The following is a description of a gene set: Aplasia/Hypoplasia of the skin species: Homo sapiens Human Gene Set: HP_APLASIA_HYPOPLASIA_OF_THE_SKIN, and this is the list of marker genes: CHRNG, DDR2, BRAF, TP53, CTNNB1, CPLX1, UBR1, WRAP53, USP48, PRKAR1A, THBS2 (thrombospondin 2), NFIX, PROC, PTDSS1, ABL1, ZMPSTE24, DLL4, ARFGEF2, GNA11, EFEMP1, DKC1, TINF2, XPA, GORAB, TAF1, CHUK, ZNRF3, TNFRSF1B, SOX18, COL12A1, TNXB, ZFX, ADA2 (NCBI Gene Id 51816), DSP, CD28, FKBP14, GNAS, DLG4, ERCC3, ALX4, PPARG, CDKN2A, FERMT1, MSX2, TNFRSF11A, COL6A1, ERCC4, ACD, COL5A2, PLEC (NCBI Gene Id 5339), COL5A1, DHX30, KRT14, ANAPC1, RTEL1, CAV1, DDB2, PIGG (NCBI Gene Id 54872, phosphatidylinositol glycan anchor biosynthesis class G (EMM blood group)), CDH1, SMAD2, WNT10A, TERC, KCTD1, BMS1, MGP, CTSC, KRT5, CDH23, HSPA9, POLR3A, TERT, KDF1, XPC, RECQL, KLHL24, AHDC1, ATM, TRAF6, ARF1, EOGT, ARMC5, LSS, AEBP1, RBPJ, LOX, CTC1, ITGA6, SLC29A3, LRP1, PEPD, ABCC6, CHD8, SPEN, CTBP1, COL17A1, DST, CUL4B (NCBI Gene Id 8450), DSE, SLC2A10, UBA2, TGFBR1, NSD2, TFAP2A, ADNP, SMAD3, SMO, TGFBR2, PLOD1 (procollagen-lysine,2-oxoglutarate 5-dioxygenase 1), FMR1 (NCBI Gene Id 5421), ADAMTS2, ARHGAP31, TGFB2, ADAMTSL2, MMP1, KRAS, CHST14, ERCC6, EDAR, SMARCAD1, MTAP, FOSL2, NOTCH1, CTLA4, POLD1, USB1, NR3C1, TYMS, LMNA, NOP10, PRKD1 (protein kinase D1), GSN, UBE3B, ORC1, FLNA, ITGB4, CHD6, AIP, SLC39A13, NHP2, IPO8 (NCBI Gene Id 10526), PDGFRB, COL3A1, ARL6IP6, USP8, PIK3R1, PROS1 (NCBI Gene Id 5627), FGFRL1, WRN, COL6A3 (collagen type VI alpha 3 chain), CARMIL2, COL1A2, B3GALT6, HCCS, TWIST2, KRT2, ALDH18A1, TMTC3, ATRX, PDE11A, COX7B, BGN, NDUFB11, ENPP1, PYCR1, C1R, ATP6V1B2, KDM1A, FBN1, TCIRG1, RECQL4, NEDD4L, FBXO11, PARN, COL6A2, MYH3, PORCN, LIFR, MCTP2, RBCK1, TGFB3, MAP1B, LETM1, C1S, DHCR24, ERCC5, MVK, ERMARD, DOCK6, COL1A1, ERCC2, COL7A1, ANTXR2, TP63, ALG9, LAMB3, NELFA, EDA, SATB2, B4GALT7, PPP1CB, COPB1, IFT140, LAMA3, POLH, NPM1, LAMC2, EDARADD, PMVK